Given this list of marker genes DZIP1L, TCF4, AKR1D1, APOB, FOCAD, SEMA4D, GBA2, TTPA, EFL1, CYP7A1 (NCBI Gene Id 1581), SBDS, SLC30A10, AMACR, MST1, GPR35, DNAJC21, PKHD1, SLC51B, MTTP, here is a description of the gene set: species: Homo sapiens Concentration of vitamin E in the blood circulation outside of normal limits. Human Gene Set: HP_ABNORMAL_CIRCULATING_VITAMIN_E_CONCENTRATION Abnormal circulating vitamin E concentration